The following is a description of a gene set: species: Mus musculus Mouse Gene Set: GOMF_SODIUM_PHOSPHATE_SYMPORTER_ACTIVITY Enables the transfer of a solute or solutes from one side of a membrane to the other according to the reaction: Na+(out) + phosphate(out) = Na+(in) + phosphate(in)., and this is the list of marker genes: Slc34a2, Slc17a8, Slc20a1, Slc34a3, Slc17a7, Slc34a1, Slc17a6, Slc20a2